Given this list of marker genes CELF2, TRAF3IP3, FOXI1, FAM168B, LHCGR, EIF2AK1, APRT, ZNF749, CDC14B, PMS2, NIT1, ABCA6, REEP5, GLB1L2, MTMR11, LIPA, PIGCP1, TAF1, DTNA, P2RY10, GAMT, ALDH6A1, TAGLN, POSTN, RAG2, ROS1, CCL23, ATG13, OSMR, HYAL1, INHBA, ZFP36, NORAD, SNED1, TRAK1 (NCBI Gene Id 22906), MOXD1, LIMK2, BCHE, PRRG2 (proline rich and Gla domain 2), FGFR1, ADAMTS2, VDAC1P3, VAPB, BRSK2, FADS1, DYRK4, FZD2, MMP3, THBS2, FPR2, ZHX3, PNOC, YIPF3, EEA1 (NCBI Gene Id 8411), LOX, PTPRD, JUND, PDGFRL, CD151, RNF19B, ASPH, RBM15B, DPP4, ZSCAN12 (NCBI Gene Id 9753), DGCR6, UBA7, PLP1, SLC12A1, TMCO6, NEK1, LIMS1, ABCB6, HBZ, ZFHX3, DUSP1, LAMB1, ATP2C1, TOX4, SPG7, PDIA5, EFEMP2, IGHV1-2, SDC1, C8G, MYB, IFT88, OLFML2A, ACTR1B, CSRP2, ZFP36L2, IFT20, ACY1, EFEMP1, BSCL2, NFIB, NFATC4, IFNG (NCBI Gene Id 3458), PER2 (period circadian regulator 2), STK25, SGSM3, PSMB8, IGFBP3, ZNF135, JUN, ADCYAP1R1, LMOD1, CAMP (NCBI Gene Id 820), TRPC2, HRAS, UCP3, NFASC, PRAF2, GOLGA2, NDUFA6, ZNRF4, NMNAT2, THBS3, CETN2, ENSG00000291006, TNFSF11, FLT3LG, DDIT3, GRM8, RUFY3, HNRNPU, IPO8, ACHE, SERPINB10, IFI35, DMXL1, MAPK11, CPSF1, PTGIR, ERBB2, RER1 (retention in endoplasmic reticulum sorting receptor 1), VDR, CCDC85B, SSPN, MOCS3 (NCBI Gene Id 27304), SAA4, TTN-AS1, C1orf21, ACTG1, ZFPL1, LAMC2, MBOAT7, PHF20, LMO7, RPL29P17, RIOX2, PEMT, DYRK2, RASA4, VPS39, CDC40, BCKDK, SVEP1, CCDC22, SSX2, VRK2, FRMPD4, MAS1, SPPL2B, PLAUR, ADD1, PRR3, CXCL6, KAT6B, CEP170B, TULP3, GPR12, UCKL1, C3AR1, GFAP, FKBP8, SERPINH1, GOLIM4, CRMP1, RENBP, DHFR, KCNK3, SLC7A7, ATXN3, PAX2, H2AC16, AOX1 (aldehyde oxidase 1), MTR, PCSK7, CLCA1, ATG5, IQSEC3, ETV1, FOLR2, FARP2, BTBD2, MGRN1, CORO1A, NTRK2, LY6E, RUNX1T1, MT1G, HAS2, NPIPB3, MAP1B, PCGF2, PCK1, CACNA1C, KLHL9, DOK1, COL6A2, CAPNS1, MAP2, CBY1, DUSP9, SLC16A5, TK2, DMAC2L, PRKAA1, TEP1, H4C9, SEC16A, RIF1, ENPP2, OPRD1, EPAS1, SGCD, CALR, BTN3A2, TSPAN31, CXCL13, RCAN2, GDF10, JCAD, CUBN, NCK1, MASP1, SPTB, HSPB6, NGF, ANXA2, WSCD1, CPSF6, OCA2, SIGLEC6, TBC1D9B, ITGA3, IGFBP6, HSPG2, CSH1, MUC1, PBX1, ALMS1, ATRX, AGTR2, COL11A1, ERLIN2, IFITM2, KRT5, SPP1, IGFBP5, MICAL2, RAB5B, PIR, SH2D1A, MVD, OPN1SW (NCBI Gene Id 611), PTP4A1, ENPP1, SHC2, TBCD, MAGEA12, OR1E1, RAD52, FLNA, SULF1, MAGEA10, SPRYD7, PSG11, EML2, STK17A, MAZ, ATOSB, PTPRO (NCBI Gene Id 5800), COL6A1, DLGAP4, CEL, AKT3, NAP1L3, TGFBI, RNF10, LGALS3BP, CACNA1A, DLGAP1, ABCA4 (NCBI Gene Id 7815), TJP1, FGF13 (fibroblast growth factor 13), SAMD14, LOXL2, SKAP1, S100A13, PIK3R3, MDFIC, PRMT2, MAP2K5, BICRAL, ARHGEF11, XYLT1, TPM4, UBE3A, PTGDR2, UBE2I, SH3BP2, CRABP2, FADS3, RPL23, SOCS3, PLA2G6, RNASE4, NISCH, NCR1, SIX1, CTBS, GHRHR, PPP6R2, CDC42EP2, TRAPPC6A (trafficking protein particle complex subunit 6A), FN1, ITPKA, PSCA, MAP2K6, SRI (sorcin), MSC, RAI14, EMP3, RNF216P1, COL16A1, MYH11, ACADVL, CHST3, CRHR2, RNF41, RASGRP2, IGFBP4, LPP, ZYX, ITGA4, SLC22A18, LAMA2, EN2, GJA1, MUC6, FBLN5, RNH1, MMP16, TDRD3, HMBS, ANGEL1, TRIO, FOXO3, ROM1, NKTR, PLXNC1, GZMK, AP4M1, RBPMS, PTPN21, ESM1, GABRA1, PPARG, INSL3, ACP3, UBE2L3, LZTS3, RAB3B, MAN2B2, RRAS2, GCDH, ECM2, RFX1, CXCL12, NAP1L1, AKR7A3, SNX29 (NCBI Gene Id 92018), SLCO2A1, IDUA, CHML, IFT70A, PLCD1, DCTN1, MAPK14, DYNC1I2, ITGB2, CEP162, ACACB, SYCP1, RAB2A, ARHGAP6, OPRK1, EMX2, STAT1, GDF11, RBMS1P1, WIPI1, PAX4, RS1 (NCBI Gene Id 6247), MYF5, PIP, PKMYT1, SDC2, MTA1, SLC6A3, MLN, FADS2, CDH6, RHOQ, FKBP9, ZNF710-AS1, PCF11, CA12, TCF3, PRUNE2, GALE, GABPB1, ZSCAN26, HSPA4, AR, SELENOP, ANK1 (ankyrin 1), DENND2B, PPP2R3A, CFH, SERPINB7 (serpin family B member 7), MLH1, CDH16, DHRS1, TGFB1I1, PRKD3, TCTA, MYL9, CAVIN1 (caveolae associated protein 1), SLC13A3, TSPAN6, HBB, PSG4, CHEK2, PCDH1, LYRM9, PTPN11, LPIN1, MEIS3P1, EPB42, FAP, OR2H2, PVALB, CDR1, NR1H3, PSG3, FCMR, NEK7, SLC16A7, MANBA, CCND1, CXCR2, TMEM109, ATP2C2, LTBP2, SLC7A1, PON1, PTGER1, HOXD3, PRAMEF1, EP400, CCL27, MYBPC3, MATN2, GJC1, RAP2A, PYY, MPG, CD1E, DDR2, here is a description of the gene set: from publication Browne EP, Wing B, Coleman D, Shenk T (PMID 11711622) Genes down-regulated in primary fibroblast cell culture after infection with HCMV (AD169 strain) at 48 h time point that were not down-regulated at the previous time point, 24 h. species: Homo sapiens Human Gene Set: BROWNE_HCMV_INFECTION_48HR_DN The effect of human cytomegalovirus (HCMV) infection on cellular mRNA accumulation was analyzed by gene chip technology. During a 48-h time course after infection of human diploid fibroblasts, 1,425 cellular mRNAs were found to be up-regulated or down-regulated by threefold or greater in at least two consecutive time points. Several classes of genes were prominently affected, including interferon response genes, cell cycle regulators, apoptosis regulators, inflammatory pathway genes, and immune regulators. The number of mRNAs that were up-regulated or down-regulated were roughly equal over the complete time course. However, for the first 8 h after infection, the number of up-regulated mRNAs was significantly less than the number of down-regulated mRNAs. By analyzing the mRNA expression profile of cells infected in the presence of cycloheximide, it was found that a minimum of 25 mRNAs were modulated by HCMV in the absence of protein synthesis. These included mRNAs encoded by a small number of interferon-responsive genes, as well as beta interferon itself. Cellular mRNA levels in cytomegalovirus-infected cells were compared to the levels in cells infected with UV-inactivated virus. The inactivated virus caused the up-regulation of a much greater number of mRNAs, many of which encoded proteins with antiviral roles, such as interferon-responsive genes and proinflammatory cytokines. These data argue that one or more newly synthesized viral gene products block the induction of antiviral pathways that are triggered by HCMV binding and entry.